Given this list of marker genes POLR3GL, ST14, REPIN1, TOMM40L, HMG20B, RCN1, ZWILCH, PIP4P2, WRNIP1, ABCB7, SLC25A16, ETS1, ATAD2 (NCBI Gene Id 84325), CEP15, SOCS2, DCK, NUP210, GJD2, PRKAR1A, IRF1, C1orf21, RBKS, ANXA6, FUOM, TPST2, ZDHHC16, GPR146, GPN2, F2R (coagulation factor II thrombin receptor), TM9SF1 (NCBI Gene Id 10548), CBX5, GIMAP4, NCAPD2, AP1G2, CD164, DBNL, CRACDL, TAFA3, ATXN10, ARL6 (NCBI Gene Id 84100), HEMK1, C2orf42, EIF2AK3, CC2D2A, TNRC6C, UBE2M, RPL24, CFL1, TCF19, STAT1, RPL3, TAP2, SPATA13, HSD17B4, EXOC2, PTPN9, UAP1, RASIP1, CNN2, SPTSSA, GPM6A, CCDC124, GRK6, ETFDH, TEX2, MOB3A, CTSW, NHERF1, F2RL3, ARF5, CHURC1, CDC20B, PTPN1, NTSR1, LY6E, FUS, LGALS9B, RNF135 (NCBI Gene Id 84282), NDRG2, VPS72, GSTO1, MIEN1, HMG20A, PPM1H, MYH9, PCCA, AUH, ABHD8 (NCBI Gene Id 79575), TREX1, PRMT2, TPCN1, RBL1, RAB1B, CSK, SEMA4A, CLASP1, BAG1, MYBL2, ZSCAN22, VPS9D1, ESPL1, PFN2, DOK2, VGLL4, BMP2K, TRMT2B, CETN3, MBNL1, ARL4C, TUBA3C, ALG1, ATP8B2, ARHGEF1, MBD1, ARB2A, USP18, PACS1, VAV3, RLIG1, FKBP3, VRK1, TRAPPC9, STAG1, FAM229B, SUPT20H, RASAL3, GALNT12, LRIG2, AKAP14, HP1BP3, SPTBN1, STRADA, ATP5PB (NCBI Gene Id 515), VRK3, CBX4, BANP, WDR83, TRIOBP, TCTA, FGFR1OP2, GSTO2, TCF3, NSF, ABHD17A, RNASEL, FKBP8, PHKB, PTP4A3, RECQL, ADD1, TMEM92, SMAP2, TBC1D10C, PDIA4, CYTH1, DTX3L, GEN1, MBD2, NMRAL1, ENO3, NCAPG2, GALNT2, SCAPER, ESM1, KCNAB2 (potassium voltage-gated channel subfamily A regulatory beta subunit 2), BCL2L11, MAN2B1, TMEM267, SKA1, GTF2H4, RASGRP1, HECTD3, AP5M1, WASHC4, GPR171 (NCBI Gene Id 29909), SRR, EEIG1, HLA-DMA (NCBI Gene Id 3108), ARHGAP4, ABCB6, CSNK1G2, OGDH, MTX2, PPP3CA, PRPS2, TEX9, LIMK1, PHF20L1, RPGR, AP3M1, C2CD5, VPS37B, ZMAT5, CCDC47, CHRNA5, BPHL, IL10RA, MRI1, here is a description of the gene set: studied in species Homo sapiens from publication Hinrichs CS, Borman ZA, Cassard L, Gattinoni L, Spolski R, Yu Z, Sanchez-Perez L, Muranski P, Kern SJ, Logun C, Palmer DC, Ji Y, Reger RN, Leonard WJ, Danner RL, Rosenberg SA, Restifo NP (PMID 19805141) Human Gene Set: GSE16522_ANTI_CD3CD28_STIM_VS_UNSTIM_NAIVE_CD8_TCELL_DN Genes down-regulated in comparison of stimulated naive CD8 T cells from pmel-1 mice versus unstimulated naive CD8 T cells from pmel-1 mice. Effector cells for adoptive immunotherapy can be generated by in vitro stimulation of naïve or memory subsets of CD8+ T cells. While the characteristics of CD8+ T cell subsets are well defined, the heritable influence of those populations on their effector cell progeny is not well understood. We studied effector cells generated from naïve or central memory CD8+ T cells and found that they retained distinct gene expression signatures and developmental programs. Effector cells derived from central memory cells tended to retain their CD62L+ phenotype, but also to acquire KLRG1, an indicator of cellular senescence. In contrast, the effector cell progeny of naïve cells displayed reduced terminal differentiation, and, following infusion, they displayed greater expansion, cytokine production, and tumor destruction. These data indicate that effector cells retain a gene expression imprint conferred by their naïve or central memory progenitors, and they suggest a strategy for enhancing cancer immunotherapy.